Given this list of marker genes NDFIP1, TBX21, IL27RA, ARG2, ANXA1, CCR2, HLX, STAT6, BCL6, IFNA2, IFNL1, ASCL2 (NCBI Gene Id 430), IFNB1, SOCS5, ARG1, here is a description of the gene set: Any process that stops, prevents, or reduces the frequency, rate, or extent of a type 2 immune response. studied in species Homo sapiens Human Gene Set: GOBP_NEGATIVE_REGULATION_OF_TYPE_2_IMMUNE_RESPONSE